The following is a description of a gene set: species: Homo sapiens mouse primary BMDCs were stimulated with tlr ligands and gene expression changes were profiled on Affymetrix arrays Human Gene Set: GSE17721_ALL_VS_24H_PAM3CSK4_BMDC_UP from publication Amit I, Garber M, Chevrier N, Leite AP, Donner Y, Eisenhaure T, Guttman M, Grenier JK, Li W, Zuk O, Schubert LA, Birditt B, Shay T, Goren A, Zhang X, Smith Z, Deering R, McDonald RC, Cabili M, Bernstein BE, Rinn JL, Meissner A, Root DE, Hacohen N, Regev A (PMID 19729616) Genes up-regulated in comparison of dendritic cells (DC) stimulated with Pam3Csk4 (TLR1/2 agonist) at all time points versus those stimulated with Pam3Csk4 (TLR1/2 agonist) at 24 h only., and this is the list of marker genes: ANXA2, ITPR1, MRPS28, GPX3, CD74, CCL13, EBNA1BP2, TIMP2, EMP3, PFKP, UBE2E1, ARHGAP10, PSME1, ADAMTSL5, ACTR1A (actin related protein 1A), PPP1R14B, HSPA5, ARPC5, MCRIP1, CSF1, NECAP2, TUBB6, COTL1, LGALS3, HLA-DMB, TMEM191C, CA2, VWA5A, CACUL1, MYD88, UBL4A, JPT1, VWF, SMYD2, GJA10, GALNT3, GDAP2, APOE, SPP1, LPL, CBLN1, CLEC7A, CFDP1, HLA-DQA1, RPS6KA4, SLC25A13, MRPL54, IL11RA, ETFA, NUP58, MANF, ID2, CAPZA2, ENAM, DDX39A, FKBP1A, TGFBR1, SEPTIN8, SUV39H2, DNMT3A, TDRD7, CCL17, CEBPB, TBCB, SEC61A1, LCAT, SLC5A2, CAPZB, YIF1A, CFP, PTPRO, EPS15L1, ITGAX, BRI3, AGO2, CLTB, KCNN4, OSBPL6, AIRN, TGFB1, SNX12, RANBP1, SNX6, PLAUR, TPSB2 (tryptase beta 2, NCBI Gene Id 90686), CIITA, PITRM1, GTF3C6, CAPN2, MYBPH (NCBI Gene Id 4608), MAT2A, SLC7A8 (solute carrier family 7 member 8), ATAD2B, HLA-DRB1, UTP20, SMS, NLN, ROPN1, TMEM150A, NOL12, ANPEP, TBC1D13, USP25, PRELID3B, SRP68, VAT1, ARID3B, ZYX, EVL, PHYKPL, RIN2, SLFN12L, DDX39B, UTP18, PTRH1, UBE2L6, IGF2R (NCBI Gene Id 3482), ARHGAP1, FGR, RRP9, UAP1L1, ATP2B2, SGCB, SELENOT, TACSTD2, EIF5A, PRRC1, ALDH1A2, ANXA4, TUBB2A, C2CD2, CA4, PCSK7, CLCN5, CPA2, KBTBD2, IL7R, CHMP3, P2RY14, MAPRE2, P2RX5, F10 (coagulation factor X), PRKCD, SPEG, LTBP4, QPCT, CFL1, MITF, SLAMF8, MYO9A, CLEC10A, CCDC86, MAPK6, PSMB10, SNAP29, COLGALT1, NSMCE2, NOP58, CTSS, LECT2, SEPTIN2, RRBP1, GATM, HTT, LYPLA2, SLC30A4, CAPG, GRB10, CTSB, SCGB3A2, IFIT2, ANKRD26, IL1RN, SGK3, CD53, TDRP, HEYL, RBM3, VIM, AIDA, MRTO4 (NCBI Gene Id 94394), PSAP, CRLF2, HGSNAT, TOR1AIP1, GTF3C5, RPS6KC1, GBP7, LSP1 (NCBI Gene Id 4046), PDIA6, ANXA1, IGF1, TRAF5, SMC6, HBEGF, ATP6V1G1, ALYREF, FGF13, RNASE2, ECE2 (endothelin converting enzyme 2)